The following is a description of a gene set: from publication Prots I, Skapenko A, Lipsky PE, Schulze-Koops H (PMID 21347372) studied in species Homo sapiens Human Gene Set: GSE24634_IL4_VS_CTRL_TREATED_NAIVE_CD4_TCELL_DAY10_UP Genes up-regulated in comparison of CD25- T cells treated with IL4 at day 10 versus untreated CD25- T cells at day 10. CD25+ regulatory T cells develop in the thymus (nTregs), but may also be generated in the periphery upon stimulation of naive CD4 T cells under appropriate conditions (iTregs). The mechanisms that regulate the generation of peripheral iTregs are largely unknown. We used microarrays to gain insights into the molecular program of extrathymic Treg development., and this is the list of marker genes: HPGDS, SEMA6D, ITPKB, TP53BP1, SNAP25, PGM1, TTN, TREM1, MYB, GLMN, ASCL3, DNASE1L3, ALOX15B, ZNF512B, PLEKHB1, KCNK7, BCHE, SLIT2, MLLT11, BCL2, EXTL2, RRM2, DIPK1A, TNNI3K, SMC4, CKAP2 (NCBI Gene Id 55221), STIL, ISG20, GPA33, CENPF, ABCG2, CD3D, GYPC, BLMH, GCAT, IL24, LGR4 (NCBI Gene Id 55366), TRIM32, GPR35, KCNK5, FNBP1, PNPLA3, AGK, NFATC3, SLCO2B1, ATP5MC2, CCL17, C19orf53, IL1R2, SH2D1A, SELENOP (NCBI Gene Id 6414), PLXNC1, SLC7A6, EIF2S3, SIGIRR, TRAF3IP3, RFX3 (NCBI Gene Id 5991), KIF11 (NCBI Gene Id 3832), ZFTA, CD2, SMC5, SEPTIN9, ONECUT2, IL16, TNFRSF4, LCN2, BUB1, MTMR2, TRPA1, CPOX, VPS13B, FCMR, HMGB3P1, CD27, AIRE (NCBI Gene Id 326), FABP4, LAPTM4B, PRRG3, NBPF10, GOLPH3L, C1orf21, VPS8, PTGER4, CCL13, SFI1, MBIP, ITM2A, CPEB1, AEBP1, SIRPG, DLEU1, METTL8, ADORA3 (NCBI Gene Id 140), ELP4, STK39, PBXIP1, SERF2, GFI1, GPR183, ARHGDIB, BPTF, TYMS, THYN1, STMN1, UCP2, GINS2, STAP1, RASGRP1, KRT2, DNAAF2, NFKB1, H4C3, CCL24, LRRC1, F13A1, LRBA, MERTK, FBXO41, CKS2, TDRD1, CFP, PIP5K1B, VWF, OLFML2B, GTF3C4, CD96, CDKN3, RHPN1-AS1, GFRA1, JHY, WASF3, SEMA4D, GREM2, POGLUT2, CAMK2G, DKC1, REEP2, TSPAN13, CEP97, CNTRL, FANCI, MRPL48, ITGA4, OIP5, LRRN3, IL17RB, PCSK7 (NCBI Gene Id 95070), KLHL23, ATP2A1, HOXC11, DAD1 (NCBI Gene Id 1603), ITGBL1 (integrin subunit beta like 1), TRBC1, INPP4B, HERC1, LRP2BP, GATA3 (GATA binding protein 3), TDRKH, ADAM19, CD93, MARCKSL1, DPY19L1, CCDC81, PEBP1, KRT17, STAT4, CCL18, OSM, IGLL3P, PNN (NCBI Gene Id 5411), SUPT20H, NMB, LCP2, PREX2, CALM3, TMEM223, JPT1, GPSM3, RAMP1, OPA3, KCNMB4, P2RX5, FOXO1, AQP4, ID2, MARCO, SKAP1, ANXA6, CBX5, SLC35F2, OLA1, TUT4, CD200, ICA1, TOP2A, DCX, EHD1, ASB8